Given this list of marker genes Sdk1, here is a description of the gene set: studied in species Mus musculus Reactome Pathway: SDK interactions This event has been computationally inferred from an event that has been demonstrated in another species.<p>The inference is based on the homology mapping from PANTHER. Briefly, reactions for which all involved PhysicalEntities (in input, output and catalyst) have a mapped orthologue/paralogue (for complexes at least 75% of components must have a mapping) are inferred to the other species. part of: Cell-cell junction organization electronically inferred by orthology from the curated human pathway